The following is a description of a gene set: Genes in the cancer module 87. species: Homo sapiens Human Gene Set: MODULE_87, and this is the list of marker genes: SCG5, NRAS, GNG10, RAB31, RHOH, EEF2, SUCLG1 (succinate-CoA ligase GDP/ADP-forming subunit alpha), MTIF2, RHEB, CDC42, ARF1 (NCBI Gene Id 375), EEF1A1, RAB11A, RRAGA, EIF2B1 (eukaryotic translation initiation factor 2B subunit alpha), RAB27A, RAB8A, RAP2A, SEPTIN6, RAB2A, TUBB4B, RAB33A, OPA1, RAB5A, RALA, ARF5, TUBA4A, GEM, RAP1B, PCK2, GNAI3 (G protein subunit alpha i3), RAB5C, ARL3, GNA12, RAP1A, RAN, ARL2, RIT1, ARL1, GNA13 (NCBI Gene Id 147219), TRIM23, RALB, ARF4, GNAS